Given this list of marker genes RIN2, CXCL5, CXCL1, NNMT, CD70, OCIAD2, LASP1, PLK2, TRAM1, AKR1B1, DPYSL3, LGALS3BP, PPARG, COL4A6, TM2D2, LACTB, BCL2A1, ANXA3, SULF2, GPRC5B, ADGRE3, MT1X, TGFB2, CTSL, CXCL3, PTPRF, PCED1B, SPOCK1, LYSMD4, BZW1, PLAAT3, COTL1, COL4A2, ACTR3, RPL7A, PTGES, AKR1B10, MORC4, CORO1C, GSDME, SFRP1, COL11A1, RASSF10, FLNB, RNF149, MFGE8, MT2A (metallothionein 2A), FAM83D, TRNP1, TMPRSS9, VIM, GALNT10, EIF4G2, GLS, GPC1, RAB34, COL5A1, ANXA10, CALD1, DIO2, FN1 (fibronectin 1), SPARC, PRSS23, LOXL2 (lysyl oxidase like 2), MATN2 (NCBI Gene Id 4147), EPB41L2, ATOX1, PMEPA1 (NCBI Gene Id 56937), LBH, EIF5, DCBLD1, GALNT1, NXPE3, EFEMP1, HSP90AA1, NRP2 (neuropilin 2), here is a description of the gene set: Human Gene Set: BRUECKNER_TARGETS_OF_MIRLET7A3_DN Genes down-regulated in A549 cells (lung cancer) expressing MIRLET7A3 microRNA off a plasmid vector. from publication Brueckner B, Stresemann C, Kuner R, Mund C, Musch T, Meister M, Sültmann H, Lyko F (PMID 17308078) MicroRNAs (miRNAs) are small noncoding RNAs that repress their target mRNAs by complementary base pairing and induction of the RNA interference pathway. It has been shown that miRNA expression can be regulated by DNA methylation and it has been suggested that altered miRNA gene methylation might contribute to human tumorigenesis. In this study, we show that the human let-7a-3 gene on chromosome 22q13.31 is associated with a CpG island. Let-7a-3 belongs to the archetypal let-7 miRNA gene family and was found to be methylated by the DNA methyltransferases DNMT1 and DNMT3B. The gene was heavily methylated in normal human tissues but hypomethylated in some lung adenocarcinomas. Let-7a-3 hypomethylation facilitated epigenetic reactivation of the gene and elevated expression of let-7a-3 in a human lung cancer cell line resulted in enhanced tumor phenotypes and oncogenic changes in transcription profiles. Our results thus identify let-7a-3 as an epigenetically regulated miRNA gene with oncogenic function and suggest that aberrant miRNA gene methylation might contribute to the human cancer epigenome. studied in species Homo sapiens